The following is a description of a gene set: Human Gene Set: REACTOME_DEFECTS_IN_COBALAMIN_B12_METABOLISM Defects in cobalamin (B12) metabolism studied in species Homo sapiens, and this is the list of marker genes: MMADHC, LMBRD1, AMN, ABCD4, CUBN, TCN2, MMAB, MMACHC, MMUT, MTRR, MMAA, CBLIF, CD320, MTR